Given this list of marker genes ADCY8, CREB1, HTR3E, GNB5, ADCY4, ADCY7, TUBB1, RASGRF2, PRKCA, CACNG3, KCNJ9, TUBB3, NEFL, CACNG8, TUBB2B, DLG4, GNAI3, NRG1, PRKACA, TUBB8B, GABRG3, GABRA2, AP2A1, GABRA4, RAC1, ADCY3, AP2B1, GRIN2A, DLG1, CHRNB2, GNAL, NRAS, APBA1, CHRNA7, GABBR2, CAMK2D, CACNG2, CHRNB4, TUBB4A, ERBB4, GRIK3, CAMKK2 (calcium/calmodulin dependent protein kinase kinase 2), GABBR1, GRIN2C, GRIK2, PRKAR2B, PRKAR1B, GABRA6, PPM1E, PRKCB, CHRNA5, GNG11, KCNJ12, PRKCG, ACTN2, GNG8, KCNJ3, MAPK1, GABRR1, CHRNA2, HTR3A, TUBA3C, ADCY5, PRKAG1, GABRA5, PRKX, KIF17, PRKAR1A (protein kinase cAMP-dependent type I regulatory subunit alpha), PICK1, GRIN1, GIT1, GRIN2D, PRKAG2, GABRG2, GNGT2, CAMK2G, NCALD, GRIK4, NRGN, CAMK2B, TUBA1C, GRIN3B, GNG7, LRRC7 (leucine rich repeat containing 7), GABRB3, PRKAG3, HTR3C, SRC, GNG3, GNG12, TUBB2A, GABRR2, GRIA1, PRKACB, PRKAA1, RASGRF1, TUBA1B, ADCY6, NPTN, RPS6KA1, TUBAL3, EPB41L1, CHRNG, KCNJ5, GNG5, GRIA3 (NCBI Gene Id 2892), PLCB2, KRAS, HRAS, GNG2, GNG10, GRIA2, GNB1, GNG13, MAPK3, PRKAR2A, PRKAB1, GRIA4, CHRNB3, GRIK1, CHRNA6, KCNJ2, MAPT, MDM2, GABRA3, GABRA1, GNB3, TUBA3D, GRIP1, GRIN2B, MYO6, GNAI2, AP2M1, HTR3D, PLCB1, KCNJ15, RPS6KA6, GABRB1, NSF, GABRQ, PRKACG, CACNG4, HTR3B, ARHGEF9, CHRNA4, AKAP5, CALM1, GRIN3A, KCNJ6, LIN7A, GLRA1, GRIK5, LIN7B, CHRNA3, GNAI1, GNG4, CASK, GNB4 (G protein subunit beta 4), GNAT3, PRKAB2, DLG3, CAMK4, GLRA3, TUBA1A, CHRNA9, PLCB3, RPS6KA3, ADCY1, AP2S1, CHRNE, TUBB6, GABRR3, TUBA4A, TSPAN7, TUBA8 (tubulin alpha 8), GRIP2 (glutamate receptor interacting protein 2), GNGT1, CAMKK1, CHRNA1 (NCBI Gene Id 1134), ARHGEF7, TUBB4B, AP2A2 (NCBI Gene Id 25955), KCNJ16, NBEA, PPM1F, KCNJ4, ADCY9, GLRA2, TUBA4B, CHRND, RPS6KA2, DLG2, CAMK2A, GLRB, ADCY2, TUBA3E, PRKAA2, PDPK1, KPNA2, CAMK1, TUBB8, KCNJ10, GNB2, GABRB2, LIN7C, here is a description of the gene set: The neurotransmitter in the synaptic cleft released by the pre-synaptic neuron binds specific receptors located on the post-synaptic terminal. These receptors are either ion channels or G protein coupled receptors that function to transmit the signals from the post-synaptic membrane to the cell body. species: Homo sapiens Reactome Pathway: Neurotransmitter receptors and postsynaptic signal transmission part of: Transmission across Chemical Synapses